The following is a description of a gene set: Human Gene Set: GOMF_STRUCTURAL_CONSTITUENT_OF_NUCLEAR_PORE species: Homo sapiens The action of a molecule that contributes to the structural integrity of the nuclear pore complex, a protein-lined channel in the nuclear envelope that allows the transfer of macromolecules., and this is the list of marker genes: NUP62CL, NPAP1 (NCBI Gene Id 23742), POM121, NUTF2, NUP98, NUP93, TPR, NUP58, NUP35 (NCBI Gene Id 129401), NUP107, NUP153, NUP160, POM121C, POM121B, NUP155, POM121L2, NUP62, NUP133 (NCBI Gene Id 55746), NDC1, NUP205, NUP188, NUP88, NUP214, NUP54, NUP85